The following is a description of a gene set: Genes up-regulated in SEND cells (skin endothelium) at hypoxia with ELK3 knockdown by RNAi. The ternary complex factor Net/Elk3 is downregulated in hypoxia and participates in the induction by hypoxia of several genes, including c-fos, vascular endothelial growth factor and egr-1. However, the global role of Net in hypoxia remains to be elucidated. We have identified, in a large-scale analysis of RNA expression using microarrays, more than genes that are regulated by Net in hypoxia. In order to gain insights into the role of Net in hypoxia, we have analysed in parallel the genes regulated by HIF-1alpha, the classical factor involved in the response to hypoxia. We identified about genes that are regulated by HIF-1alpha in hypoxia. Surprisingly, when we compare the genes induced by hypoxia that require either Net or HIF-1alpha, the majority are the same (75%), suggesting that the functions of both factors are closely linked. Interestingly, in hypoxia, Net regulates the expression of several genes known to control HIF-1alpha stability, including PHD2, PHD3 and Siah2, suggesting that Net regulates the stability of HIF-1alpha. We found that inhibition of Net by RNAi leads to decreased HIF-1alpha expression at the protein level in hypoxia. These results indicate that Net participates in the transcriptional response to hypoxia by regulation of HIF-1alpha protein stability. species: Mus musculus from publication Gross C, Dubois-Pot H, Wasylyk B (PMID 17704799) Human Gene Set: GROSS_HYPOXIA_VIA_ELK3_UP, and this is the list of marker genes: DTYMK, MINPP1, INIP, SRSF10, FRZB, PKD1, RACGAP1, ST3GAL4, BCL6B, SSH1, APLN, RAPGEF3, BIRC5, HELLS, RCC2, TP53INP1, CORO1C, CPT2, PPARGC1B, SLC12A2, TXNIP, CENPA (centromere protein A), MYO1C, MARCKS, TUBB4B, NHERF1, CXCL12, ABCG1, MAP2K3, ARRB1, PPRC1, DPP7, SKI, ARPP19, CDC23, PLEC, AMOT, IGDCC3, SIGMAR1, PPM1F, HOXD9, ZMAT3, FNBP1, FAS, HOXD8, GET1, PDCD4, TUBA1C, PWWP3A, PATJ, TNRC6A, SAC3D1 (NCBI Gene Id 29901), EI24, ARL6IP1, NCBP2, NDE1, EFNA5, MGAT4B, SPAG5, F2R, CHST12, WBP1 (NCBI Gene Id 96445), CDCA5, PIAS3, TOPBP1 (DNA topoisomerase II binding protein 1), RRAS2, CREBL2, CDKN2C, MKNK2, CD276, H2AJ, ARL6IP4, NDC80, SRSF2, HRAS, ARL4C, PRKAR2A, TNS1, PARVA (NCBI Gene Id 80050), CDK2AP1 (cyclin dependent kinase 2 associated protein 1), DDX39B, AMOTL2 (angiomotin like 2), PRKCH, PHLDA3, NSL1, NOTCH1 (NCBI Gene Id 54781), DOK4 (NCBI Gene Id 55715), EGLN1, SF3A1, NEDD4, JPT1, PDRG1, NAIP, SLC19A2, CBFB (core-binding factor subunit beta), ENG, CRYAB, TIMP2, PALD1, CRIP2, MAP3K11, LPCAT1, SRSF1, KPNA2, H6PD, UBE2C, DDIT4L, ACTR1A (NCBI Gene Id 10121), ULK1, AACS, SEPHS1, PLXNA1, TRIM21, STXBP5, ACP1, GNA11, DBI, ZG16, PBK, MAPK14, IFNGR2, GART, KANK2, ROBO4, MAT2A, CAV2, CHN2, AK1, CDC25A, MR1, PFN2, EHD4, NRARP, ELOVL6, KDSR, UBOX5 (NCBI Gene Id 494512), EIF1AX, TFRC, CBX6, ATOSB, NCAPD2, CASP3, RXRA, AMD1, EXO1, USP46, SETD7, SMO, AKAP8, LAMA5, NECTIN3, PYCR2, ARHGAP11A, BMP4, CTPS1, PHLDB2, NREP, MGAT2, FASN, PGAM1, GTF2E1, BCL7A, H2AX, SERINC3, ZBTB14, HES1, LGALS3BP, PTPRVP, SPAST, RAMP2, RGS12, GPX1, NAP1L1, CD81, RRM2, CCNA2, FAM89B, COL4A2, CCNB2, RBM3, TARDBP, PCMT1, TUBA1B, SCD, BRD3, STAB1, POLA2, AOX1, NDST2, DUSP7, NHERF2, SRSF5, CDC42SE1, HOXB7, NFIC, STMN1, KIF20A, AXL, PMP22, SRSF7, RPA2, CCND1, CSF1, CCNB1, CPT1A, GATA2, AJUBA, SSBP3 (NCBI Gene Id 55126), GNAQ